The following is a description of a gene set: Genes predicted to be targets of miRBase v22 microRNA mmu_miR_5620_5p, mmu_miR_7689_5p in miRDB v6.0 with MirTarget v4 prediction scores > 80 (high confidence targets). Mouse Gene Set: MIR_5620_5P_MIR_7689_5P species: Mus musculus from publication Chen Y, Wang X (PMID 31504780), and this is the list of marker genes: Ebf3, Pdzrn4, Rundc3b (NCBI Gene Id 242819), Rilpl1, Flvcr1, Ovol1, Cox7c, F8a